The following is a description of a gene set: studied in species Mus musculus The chemical reactions and pathways resulting in the formation of ribose phosphate, any phosphorylated ribose sugar. Mouse Gene Set: GOBP_RIBOSE_PHOSPHATE_BIOSYNTHETIC_PROCESS, and this is the list of marker genes: Pnp, mt-Atp6 (NCBI Gene Id 98563), Nme1, Eno1, Atp5f1b, Ampd3, Cmpk1, Adsl, Ndufa1, Uprt, Gucy2c, Atp5pd, Umps, Gmpr2, Atp5po (ATP synthase peripheral stalk subunit OSCP), Ndufc1, mt-Nd5, Ndufs7, Adcy8, Impdh2-ps, Nme4 (NME/NM23 nucleoside diphosphate kinase 4), Prps1, Ak2, Pth2, Dhodh, Ppara, Ndufs3, Cox11, Parp1, Ndufs2, Atp5pb, Nme6, Ak9, Gart, Ndufa7, Pygl, G6pdx, Adk, Fam3a, Ndufv2, Prpsap2, Il4, Ndufa6, Ak1, Sdhc, Ndufb1, Atp5if1, Atic, Ndufb10, Tgfb1, Nme5, Entpd1, Ndufa10, Atp5f1c, Impdh2, Dnajc30, Ctps1, Ampd2, Ndufa9, Uck1, Adcy6, Map2k1, mt-Nd2, Ndufb4, Papss2, Ndufb9, Atp5mc2, Ndufa8, Ndufb8, G6pd2, Papss1, Stat3, Ndufb7, Gucy2e, Upp2, Upp1, Vcp, Ndufb6, Atp5mc1, Sphk2, Ndufa5, Guk1, Antkmt, Prps2, Ndufb3, mt-Nd4, Adcy3, Atp5mg, Ndufa2, Nppc, Slc25a13, Prkn, Nme3, Myc, Ndufc2, Ndufa13, Adcy10, Paics, Ctps2, Uck2, Atp5f1d, Prps1l3, Ldhc, Adcy2, Npr2, Atp5mf, Ndufb5, Pfas, Atg5lrt, Adcy9, Atp6v1a, mt-Nd4l, Cad, Nme2, Ndufa12, Letmd1, Trem2, Ampd1, Nppb, Adcy7, Ndufa3, Atp5mc3, Dmac2l, Stoml2, Impdh1 (inosine monophosphate dehydrogenase 1), mt-Atp8, Adcy1, Adss1, Adcy5, Slc25a12, Ppat, Gucy1b1, Uckl1, Npr1, Ldhd, Prpsap1, Aprt, Aldoa, Ndufs4, Rfk (riboflavin kinase), mt-Nd3, Nme7, Nudt2, Gmps, Ndufs6, Ak3, Atp6-ps, Sdhb, Ndufs1, Ak4, Adcy4, Gmpr, Gucy2g, Tmsb4x, Atp5me, mt-Nd1, Atp5pf, Nppa, Ndufb11, Ndufa11, Gucy1a1, Ndufab1, Ndufs8, Sdhd, Sdha, Dck, Ada, Bcl2l1, Cda, Ndufs5, Lipa, Atp5f1a (NCBI Gene Id 52533), Atpsckmt, Uqcc3, Adss2, Ndufb2, Hnf1a, Eno1b, Pid1, Hprt1, Prps1l1, Gucy2d (guanylate cyclase 2d), Atp5f1e, mt-Nd6, Ndufv3, Ndufv1, Mthfd1, Gucy2f